Given this list of marker genes ENSG00000294443, RN7SL728P, NFKB1, LRRC37A15P, CXXC4, RNU6-635P, LINC02428, RN7SL89P, DDX3P3, TACR3-AS1, LINC01217, PABPC1P7 (poly(A) binding protein cytoplasmic 1 pseudogene 7), GSTCD-AS1, ARHGEF38, PPP3CA, ENSG00000249635, BANK1, RNU6-462P, TET2-AS1, LINC02173, CENPE, TET2, GIMD1, EEF1A1P9, LINC01218, INTS12, TACR3, MIR1255A, CXXC4-AS1, MANBA, LINC01216, SLC9B1, CISD2, MIR8066, RPL21P49, PIMREGP2, LINC02503, DDIT4L, UBE2D3, ATP5F1EP1 (NCBI Gene Id 23744), RNU6-553P, SLC9B2, ENSG00000254531, ARHGEF38-IT1, RPL6P14, ACTR3BP4, RNU6-351P, PPA2, AIMP1, DDIT4L-AS1, RNU7-151P, UBE2D3-AS1, NPNT, EMCN, MTND5P5, SLC39A8, BDH2, TBCK, KRT8P46, GSTCD, ENSG00000248161 (NCBI Gene Id 105377621), here is a description of the gene set: Human Gene Set: chr4q24 studied in species Homo sapiens